The following is a description of a gene set: Human Gene Set: GOMF_HETEROTRIMERIC_G_PROTEIN_BINDING studied in species Homo sapiens Binding to a heterotrimeric G-protein., and this is the list of marker genes: CETN2, ADORA1, DRD2, CETN1, ADRA2A, DRD1, CAV2